The following is a description of a gene set: An immune response against microbes mediated through a body fluid. Examples of this process are seen in the antimicrobial humoral response of Drosophila melanogaster and Mus musculus. Human Gene Set: GOBP_ANTIMICROBIAL_HUMORAL_RESPONSE studied in species Homo sapiens, and this is the list of marker genes: PF4V1, CXCL13, CXCL10 (C-X-C motif chemokine ligand 10), SPAG11B, NPPB, PRSS2, SPINK5, H2BC6, WFDC12 (WAP four-disulfide core domain 12), H2BC8, LTF, IGHM, CAMP, DEFB126 (defensin beta 126), HMGN2, LEAP2, RPL39, HRG, CCL22, BPI, RNASE6, WFDC10B, H2BC21 (NCBI Gene Id 8349), DEFA3, WFDC5 (NCBI Gene Id 23571), CCL1, CX3CL1, CCL18, REG1B (regenerating family member 1 beta), RARRES2, CXCL1, NPY, H2BC10, BCL3, CXCL12, SPON2, PRSS3, MUC7, PGLYRP3, REG3G, CCL3L3, FAU, POMC, COLEC11, APP, PGLYRP1, CCL23 (C-C motif chemokine ligand 23), CCL14, BPIFA1, CCL13, IGHG2, IGHD, CXCL6, DEFA5, PLA2G1B, PPP2R3C, DEFB131A, RNASE3, CCL7, PF4, ANG, DCD, PRTN3, CCL2 (C-C motif chemokine ligand 2), CST9, S100A12, IGHG1, TSLP, RNASE7, HTN3, IGHE (immunoglobulin heavy constant epsilon), DMBT1, CXCL3, IGHG4, F2, PGC, RNASE4, WFDC3, WFDC2, TF, ELANE, DEFB118, DEFA6, CCL17, IGHG3, CCL25, CCL5, IL36RN, CCL11, FGB, WFDC10A, CCL4, CCL3, SLC11A1, LGALS3, XCL2, CST9LP1, S100A7, HLA-A, CCL19, HAMP, RPS19, GALP, H2BC12, NTS, PPBP, RPL30, IL17F, DEFB130A (NCBI Gene Id 245940), PI3, REG3A, CALCA, CCL20 (NCBI Gene Id 6364), CXCL14, KLK5, WFDC11, CXCL5, DEFB127, IL17A, WFDC9, ADM, PLA2G6, REG1A, DEFB1, DEFB4A, DEFB103B, KLK3, KNG1, B2M (NCBI Gene Id 567), AZU1, CCL15, SEMG2, RNASE2, CCL24, CCL4L2, EVPL, H2BC4, H2BC12L, WFDC13, CCL8, DEFA1B, SLPI, VIP, CTSG, S100A9, GATA6, CCL21, HLA-E, KLK7, HTN1, IGHA1 (NCBI Gene Id 3493), LGALS4, CST9L, CXCL8, FAM3A, DEFA4, DEFB103A, JCHAIN, CXCL2, MMP7, CCL27, CCL26, ROMO1, SPRR2A, CXCL9, KRT6A, SEMG1, IGHA2, IGKV3-20, H2BC11, CCL28, ACOD1, XCL1, LYZ, GAPDH, TAC1, CCL16, FGA, GNLY, TOR2A, CXCL11, PGLYRP4, DEFA1 (defensin alpha 1), H2BC7